Given this list of marker genes Gnat2 (NCBI Gene Id 99904), Tnf, Itgb1, Myo5a, Kcnj8, Large1, Mir7116, Pomt2, Pomgnt1, here is a description of the gene set: species: Mus musculus A neuroinflammatory response, occurring over several days, during which glial cells undergo nonspecific reactive changes in response to damage to the central nervous system (CNS); typically involves the proliferation or hypertrophy of different types of glial cells. Mouse Gene Set: GOBP_REACTIVE_GLIOSIS